The following is a description of a gene set: species: Homo sapiens part of: SLC-mediated transport of oligopeptides Reactome Pathway: Proton/oligopeptide cotransporters The human SLC15 gene family encode four proton-coupled oligopeptide transporters; PEPT1 (SLC15A1), PEPT2 (SLC15A2), PHT2 (SLC15A3) and PHT1 (SLC15A4). These cotransporters are part of the Proton-coupled Oligopeptide Transporter (POT) superfamily (also called Peptide Transporter (PTR) family) (Daniel H and Kottra G, 2004)., and this is the list of marker genes: SLC15A3, SLC15A4, SLC15A1